The following is a description of a gene set: Human Gene Set: PID_NCADHERIN_PATHWAY species: Homo sapiens from publication Schaefer CF, Anthony K, Krupa S, Buchoff J, Day M, Hannay T, Buetow KH (PMID 18832364) N-cadherin signaling events, and this is the list of marker genes: CTNNA1, FGFR1, PIP5K1C, KIF5B, GSN, CDC42, GRIA2, CTNND1, AXIN1, CDH2, FER, ROCK1, MAPK8, MAPRE1, GAP43, GJA1, PIK3CA, RHOA (ras homolog family member A), CTTN, MYL2, CAMK2G, CNR1, PTPN1, PIK3R1, JUP, DAGLB, CTNNB1, PTPN11 (NCBI Gene Id 84990), LRP5, DCTN1, DAGLA, PLCG1, RAC1